The following is a description of a gene set: studied in species Mus musculus Mouse Gene Set: GOCC_AUTOPHAGOSOME_MEMBRANE The lipid bilayer surrounding an autophagosome, a double-membrane-bounded vesicle in which endogenous cellular material is sequestered., and this is the list of marker genes: Rab7, Atp6ap2, Gabarapl1, Tecpr1, Atg12 (NCBI Gene Id 67526), Chmp3, Rb1cc1, Atg4b, Entpd4, Sting1, Tex264, Wdr81, Map1lc3a, Calcoco2, Map1lc3b, Chmp1a, Atg14, Chmp4b, Tm9sf1, Lamp2, Mcoln3, Chmp6, Rab2a, Snap29, Rpn2, Prkd1, Entpd4b, Gabarap, Jmy, Chmp4c, Atg9a, Chmp5, Stx17, Rab2b, Wipi1 (NCBI Gene Id 74799), Tmem74, Tmem150b, Wdfy3, Atp13a2, Ulk1, Chmp2a, Gabarapl2, Chmp1b, Irgm1, Chmp7, Chmp1b2, Rubcnl, Chmp2b, Irgm2, Sh3glb1, Lamp1, Igtp (interferon gamma induced GTPase), Vmp1 (vacuole membrane protein 1), Uvrag, Atg16l1